The following is a description of a gene set: species: Homo sapiens Defective ST3GAL3 causes MCT12 and EIEE15 Human Gene Set: REACTOME_DEFECTIVE_ST3GAL3_CAUSES_MCT12_AND_EIEE15, and this is the list of marker genes: ST3GAL3 (NCBI Gene Id 6487), OGN, PRELP, KERA, LUM, ACAN, OMD, FMOD